The following is a description of a gene set: species: Homo sapiens from publication Yosef N, Shalek AK, Gaublomme JT, Jin H, Lee Y, Awasthi A, Wu C, Karwacz K, Xiao S, Jorgolli M, Gennert D, Satija R, Shakya A, Lu DY, Trombetta JJ, Pillai MR, Ratcliffe PJ, Coleman ML, Bix M, Tantin D, Park H, Kuchroo VK, Regev A (PMID 23467089) Despite their enormous importance, the molecular circuits that control the differentiation of Th17 cells remain largely unknown. Recent studies have reconstructed regulatory networks in mammalian cells, but have focused on short-term responses and relied on perturbation approaches that cannot be applied to primary T cells. Here, we develop a systematic strategy – combining transcriptional profiling at high temporal resolution, novel computational algorithms, and innovative nanowire-based tools for performing gene perturbations in primary T cells – to derive and experimentally validate a temporal model of the dynamic regulatory network that controls Th17 differentiation. The network is arranged into two self-reinforcing and mutually antagonistic modules that either suppress or promote Th17 differentiation. The two modules contain 12 novel regulators with no previous implication in Th17 differentiation, which may be essential to maintain the appropriate balance of Th17 and other CD4+ T cell subsets. Overall, our study identifies and validates 39 regulatory factors that are embedded within a comprehensive temporal network and identifies novel drug targets and organizational principles for the differentiation of Th17 cells. Human Gene Set: GSE43955_TGFB_IL6_VS_TGFB_IL6_IL23_TH17_ACT_CD4_TCELL_52H_UP Genes up-regulated in CD4 T helper cells Th17 (52h): TGFB1 and IL6 versus TGFB1, IL6 and IL-23., and this is the list of marker genes: RAB6A, CDC25A, KCNJ11, FZD7, MYO7A, FNTA, SEPHS1, TM4SF5, PTPN20, PCSK6, LHX9, MIX23, LTC4S, EMB, STK25, CBLIF, STRADA, TBC1D22A, ALPG, GSG1, RPLP0, CRLF3, GNAZ, TUFT1, SAR1A, MAP2K7, CYP24A1, S100A5, TMED1, RBL1, FDX1, CDC25C, PRRC2A, AP2B1, NOTCH4, XRCC5, LONP2, TOR3A, CHGB, PTS, GPANK1, ZPR1, NAA38, EFNB3, ZNF398, EN2, DRD2, MAP4K1, PML, UBA7, PTDSS2, TUBB4A, PLAT, KRT86, CXXC1, SEC11C, WDTC1, ZBED3, EEF1B2, TXNIP, NF2, IGHM, SCN9A (sodium voltage-gated channel alpha subunit 9), PENK, TMEM70, TPGS1, SDHB, PRSS8, ADRA2B (NCBI Gene Id 151), STK19, PHC1, RSRP1, ACKR4, ICA1, GRIA4, SH3BP1, ZW10, PPP4R2, CPA3, PLA2G4A, NCBP2, GSTM5, C8orf33, PHYH, COL5A1, CLN8, CCND3 (NCBI Gene Id 896), ZP3, RUVBL2, HLA-E, MKRN1, BTRC, LCAT, ZP1 (NCBI Gene Id 255714), RGS5, MTMR9 (NCBI Gene Id 83651), LLGL1, INHA, TRAIP, POLE3, ARL10, PRAP1 (NCBI Gene Id 118471), HAND2, BCL2L13, GYG1, STX5, FOXA1, TRIM27 (tripartite motif containing 27), CYP11A1, ARNT2, ELF5, SFXN2, PKP1, KIF1B, ASNSD1, DYRK1B, PAX1, ORMDL1, ADRB2, GOLT1B, FAHD1, ADH7, FAM118B, RAB4B, TRAPPC14, ARF1, BBS9, USF1, HOXB8, CMTM6, CXCL2, SERAC1, RAC3, PRPS1, TPBG, NPL, DENND5A, PICK1, RASSF5, RUNX1T1 (NCBI Gene Id 862), GHRHR, NPEPPS, GSTA5, HSD11B1, B3GALT4, BTK (NCBI Gene Id 695), CST7, CIAPIN1, FEZF2, NECAP1, ABCA4, GTPBP2, DMBT1, PRDX1, OR13J1, FBXW4, GPAM, FKBP1B, DUS1L, GNAO1, NR1H4, CNOT3, FICD, NME1, IL1R2 (NCBI Gene Id 7850), TFPT, NAA80, TCP10L, RPP21, PTRH2, UPF2, RYR1, NELFCD, RIT1, C16orf89, ARL6IP4, KCNA1, LRRC8A (leucine rich repeat containing 8 VRAC subunit A), GRK2, APLNR, CDH3, GBA2, POLD4, DNAJA1, PEX2, PDE9A, TRIM59, CUX2, SGIP1, ADGRE5, MRPL48, CYP51A1, RPS6KA3, ACOX1, YIPF1, GTF3C1, CD27, FH (fumarate hydratase), RASD1, DBNDD2